The following is a description of a gene set: Mouse Gene Set: GOBP_PROTEIN_DESUMOYLATION studied in species Mus musculus The process in which a SUMO protein (small ubiquitin-related modifier) is cleaved from its target protein., and this is the list of marker genes: Semp2l2b, Hint1, Uspl1, Semp2l1, Senp3, Senp6, Senp5, Senp2, Semp2l2a, Desi1, Senp7, Senp1